Given this list of marker genes PRPS1, TNFRSF11A, SLC37A4, SH2B1, MCFD2, UMOD, ALMS1, PHKB, PHKA2, ALDOB, SEC61A1, ADRA2A, FBP1, HPRT1, SARS2, HMGCL, LMNA (NCBI Gene Id 7816), LMAN1, PPARG, G6PC1, HNF1B, MUC1, PFKM, CLDN16, TNFRSF11B, ACAT1, MYC, PYGM, REN, here is a description of the gene set: Human Gene Set: HP_HYPERURICEMIA Hyperuricemia An abnormally high level of uric acid in the blood. studied in species Homo sapiens